The following is a description of a gene set: The directed movement of the mitochondrion to a specific location. species: Mus musculus Mouse Gene Set: GOBP_ESTABLISHMENT_OF_MITOCHONDRION_LOCALIZATION, and this is the list of marker genes: Hsbp1, Rhot2, Nectin2 (NCBI Gene Id 19294), Tspan4, Mgarp, Hif1a, Kif5b, Hdac6, Map6, Epcip, Trak1, Armcx3, Sybu, Trak2, Map1b, Agtpbp1, Agbl4, Spast, Mapt, Mark1, Wasf1, Ubb, Tspan9, Uchl1, Nefl, Pkd1, Fez1, Rhot1, Myo19, Kif1b, Actr10 (NCBI Gene Id 56444), Dnm1l, Dynll1, Kifbp